Given this list of marker genes Shox2, Tbx18, Popdc2, Maml1, Isl1, Tbx3, Bves, Tbx5 (NCBI Gene Id 21388), Bmpr1a, Nkx2-5, here is a description of the gene set: The process whose specific outcome is the progression of a pacemaker cell over time, from its formation to the mature state. Pacemaker cells are specialized cardiomyocytes that are responsible for regulating the timing of heart contractions. Mouse Gene Set: GOBP_CARDIAC_PACEMAKER_CELL_DEVELOPMENT species: Mus musculus